Given this list of marker genes ADAM21, RHO, ADAM29, ADAM30, OPN4, ADAM20, here is a description of the gene set: The plasma membrane that is part of the head section of a sperm cell. Human Gene Set: GOCC_SPERM_HEAD_PLASMA_MEMBRANE studied in species Homo sapiens